Given this list of marker genes Mir124a-2, Usp22, Smoc2, Ska1, Nanog, Cyp1a1, Cul3, Rab11a, Anapc11, Cdk1, Pbx1, Smarcd3, Tal1, Lsm10, Rps6kb1, Wnt10b, Ddr2, Prkca, Kcna5, Cpsf3, Rb1, Asns, Hmgb1, Fbxo5, Hspa2 (NCBI Gene Id 15512), Rgcc, Meis2, Poldip2, Tunar, Rrm1, Lsm11, Sass6, Lmnb1, Rcc2 (NCBI Gene Id 72534), Fgfr1, Hyal1, D1Pas1, Cdk4, Anapc5, Anxa1, Tgfb1, Mad2l1bp, Eif4g1, Cul4b, Fgf10, Lgmn, Cenpe, Eif4ebp1, Ccnb1, Pdgfb, Anp32b, Birc5, Brd4, Rptor, Stil, Pkn2, Cdc25b, Stat5b, Cdca5, Adamts1, Mta3, Rrm2, Ccnb1-ps, Phb2, Cdc16, Stox1, Mepce, Dtl, Foxa1, Neurog1, Abl1, Nsmce2, Vps4b, Rad51b, Hsf1, Kmt2e, Ccne1, Usp2, Ccne2 (cyclin E2), Cdc23, Ube2e2, Tmod3, Hes1, Shb, Dbf4, Nkx3-1, Plcb1, Rad51c, Ccnd3, Mad1l1, Eif4e, Rdx, Crebbp, Mir124a-3 (NCBI Gene Id 723951), Ttl, Cul4a, Camk2d, Ankrd17, Ube2c (NCBI Gene Id 68612), Cdc25c, Ska3, Ccnd2, Ptpn11, Pafah1b1, Ccnd1, Rpl17, Dusp3 (dual specificity phosphatase 3 (vaccinia virus phosphatase VH1-related)), Aurka, Ddx3x, App, Cdc20, Ccdc57, Cdc7, Plrg1, Stat5a, Cdc25a, Larp7, Tert, Adam17, Aif1, Rrm2b, Mir124a-1, Dynlt3, Cenpj, Brca2, Prap1, Mtbp, Egfr, Ppp1r10, Akt1, Apex1, Sin3a, Mblac1, Mdm2, Tfdp1, Sphk1 (sphingosine kinase 1), Anapc7, Klhl18, here is a description of the gene set: Mouse Gene Set: GOBP_POSITIVE_REGULATION_OF_MITOTIC_CELL_CYCLE Any process that activates or increases the rate or extent of progression through the mitotic cell cycle. species: Mus musculus